Given this list of marker genes Ino80d, Bmp3, Nup50, Rnf146, Kcnk1, Camk2d, Pabir2, Kctd21, Ints6l, Zfp930, Tab3, Elovl6, Serinc5, Cyb561, Synpo2, Sim1, Aqp4, Elovl4, Celf3, Ankrd49, Sox9, Itgav, Fbn2, Deup1, Dip2c, Adam22, Bcl2l10, Opcml, Fasl, Ubr3, Lamtor3, Tiam1, Hs3st3b1, Chml, Eif4a2, Zfp791, Rnf44, Mlec, 4931414P19Rik, Lynx1, Cavin4, Zfp772, Zfp994, Man1c1, Serpinb10, Casz1, Dgkd, Panx1, Zfp248, Thbd, Mesd, Nepn, Dek (DEK proto-oncogene), Ipo11, Ctdnep1, Kcnd3, Ret, Evc2, Eif2s2, Yod1, Igf2bp1, Pramel48, Myh10, Bpnt1, Rnf24, Sp1, Eif3j2, Kcnq2, Mpdz, Prpf4b, P4ha1 (NCBI Gene Id 18451), Jag1, Cd200l1, Adora2a, Dennd4a, Tpm2, Ubtd2, Gspt1 (G1 to S phase transition 1), Kat2b, Ppp1r3b (NCBI Gene Id 330736), Stat3, H2-Q7, Igfbp5 (NCBI Gene Id 98676), Unc5cl, Ppp4r3b, Rfxap, C1galt1, Rev3l, Nfx1, Skint3, Pgm3, Cpd, Adam17, Polr1f, Nsrp1, Tgm2, Scn7a, Pkp4, Slx4ip, Clvs1, Lipk, Lrrc19, Pard6g, Wt1, here is a description of the gene set: Mouse Gene Set: MIR_6902_5P Genes predicted to be targets of miRBase v22 microRNA mmu_miR_6902_5p in miRDB v6.0 with MirTarget v4 prediction scores > 80 (high confidence targets). from publication Chen Y, Wang X (PMID 31504780) studied in species Mus musculus